Given this list of marker genes SNAPC4, SNAPC1, ZC3H8, POLR3B, ELL, SNAPC5, SNAPC3, ICE1, ICE2, here is a description of the gene set: species: Homo sapiens Human Gene Set: GOBP_SNRNA_TRANSCRIPTION_BY_RNA_POLYMERASE_III The synthesis of small nuclear RNA (snRNA) from a DNA template by RNA Polymerase III (Pol III), originating at a Pol III promoter.